Given this list of marker genes Scnn1a, Clasp1, Cald1, Spta1, Lasp1, Gys2, Shroom1, Flot2, Cdh2, Sele, Nos2 (nitric oxide synthase 2, inducible), Pjvk, Hip1r, Myo1e, Hfe, Misp, Rtkn, Shroom3, Flot1, Cotl1, Myo1f, Pdlim2, Pvalb, Gsn, Cap1, Clasp2, Pde4dip, Cib2, Piezo1, Slc4a1, Pclo (NCBI Gene Id 26875), Flna, Pls1, Tmc2, Mpp1, Hip1, Med28, Actb, Mapre1 (NCBI Gene Id 99354), Dbn1, Actn2, Actn3, Lancl2, Krt19, Vcl, Iqgap1, Cdh1, Bsn, Myzap (NCBI Gene Id 553150), Gypc, Akap13, Slc2a1, Hcls1, Dbnl, Ocm, Mtss2, Eef1a1, Cobl, Dlg4, Sptb, Gmfb, Calb2, Capzb, Prkcb, Trpc4, Myrip, Tpm4, Numa1, Capza3, Epb42, Sptbn4, Fchsd1 (NCBI Gene Id 319262), Rapgef3, Nsmf, Wdr1, Calb1, Sptbn1, Tpm3, Sptbn2, Capza1b, Ank1, Shroom4, Myadm, Llgl2, Coro1a, Rdx, Snx9, Myh2, Inpp5d, Actn4, Gmfg, Trpv4, Capza2, Llgl1, Cttn, Ppp1r9a, Epb41, Ppp1r9b, Dmtn, Mlph, Septin2, Sptan1, Nf2, Tmod1, Maea (macrophage erythroblast attacher), Sptbn5, Dstn, Capza1, Shroom2, Plekhh2, Myh9, Actr2, Kncn, Wasl, Cldn5, Cfl1, Actn1, Myo1a, Piezo2, Dlc1, Anln, Pstpip1 (NCBI Gene Id 19200), here is a description of the gene set: The portion of the cytoskeleton that lies just beneath the plasma membrane. Mouse Gene Set: GOCC_CORTICAL_CYTOSKELETON species: Mus musculus